Given this list of marker genes FBXW7, RBX1, SKP1, NOTCH1, CUL1, here is a description of the gene set: Human Gene Set: REACTOME_FBXW7_MUTANTS_AND_NOTCH1_IN_CANCER FBXW7 Mutants and NOTCH1 in Cancer studied in species Homo sapiens